The following is a description of a gene set: Keratin. Human Gene Set: MODULE_298 studied in species Homo sapiens, and this is the list of marker genes: PTGDS, KRT6B, KRT7, KRT85, KRT17, KRT6A, NEFL, KRT18, KRT4, KRT15, KRT19, KRT5, KRT13, DSP, INA, KRT32, KRT16, KRT2, KRT8, KRT86, KRT33B, SPRR1B, KRT14, KRT35, DRD2, KRT1